The following is a description of a gene set: Human Gene Set: GOBP_NEGATIVE_REGULATION_OF_HETEROCHROMATIN_FORMATION Any process that stops, prevents, or reduces the frequency, rate or extent of heterochromatin formation. studied in species Homo sapiens, and this is the list of marker genes: DNMT3L, PHF8, RLF, PHF2, KMT2A, DYRK1A